Given this list of marker genes Thoc5, Plcb1, Ndp, Nkx2-3, Lif, Nfix, Hcls1, Zbtb46, Bmp4 (NCBI Gene Id 12159), Arid3c, Vegfa, Ifng, Csf1r, Enpp1, Cflar, Il1rl1, Rb1, Myd88, Il33, Ighe, Naglu, Nr3c1, Itgam, Spib, Qki, Gba1, Cebpe, Adipoq, C1qc, Gab3, Il34, Ror2, Trib1, Epsti1, Tlr4, Cd4, Spi1, Ucp2 (uncoupling protein 2 (mitochondrial, proton carrier)), Csf1, Sirt1, Il15, Cebpa, Casp8, Nrros (NCBI Gene Id 224109), Fosl2, Id2, Gata3, Csf2 (colony stimulating factor 2 (granulocyte-macrophage)), L3mbtl3, Mfsd8, Diaph3, Vps54, Hsf1, App, Gata2, Fadd, Vps13a, Prkca, Tspan2, Asxl2, Tgfb1, Ccdc39, Ptpn2, Large1, Socs1, Eif2ak1, Ripk1, Tlr2 (NCBI Gene Id 24088), here is a description of the gene set: species: Mus musculus Mouse Gene Set: GOBP_MACROPHAGE_DIFFERENTIATION The process in which a relatively unspecialized monocyte acquires the specialized features of a macrophage.